The following is a description of a gene set: Human Gene Set: PHONG_TNF_TARGETS_DN from publication Phong MS, Van Horn RD, Li S, Tucker-Kellogg G, Surana U, Ye XS (PMID 20516219) species: Homo sapiens Genes down-regulated in Calu-6 cells (lung cancer) at 1 h time point after TNF treatment. p38 mitogen-activated protein kinase (MAPK) is rapidly activated by stresses and is believed to play an important role in the stress response. While Chk1 is known to mediate G(2) DNA damage checkpoint control, p38 was also reported to have an essential function in this checkpoint control. Here, we have investigated further the roles of p38 and Chk1 in the G(2) DNA damage checkpoint in cancer cells. We find that although p38 activation is strongly induced by DNA damage, its activity is not required for the G(2) DNA damage checkpoint. In contrast, Chk1 kinase is responsible for the execution of G(2) DNA damage checkpoint control in p53-deficient cells. The inhibition of p38 activity has no effect on Chk1 activation and gamma-H2AX expression. Global gene expression profiling of cancer cells in response to tumor necrosis factor alpha (TNF-alpha) revealed that p38 plays a strong prosurvival role through the coordinated downregulation of proapoptotic genes and upregulation of prosurvival genes. We show that the inhibition of p38 activity during G(2) DNA damage checkpoint arrest triggers apoptosis in a p53-independent manner with a concurrent decrease in the level of Bcl2 family proteins. Our results suggest that although p38 MAPK is not required for the G(2) DNA damage checkpoint function, it plays an important prosurvival role during the G(2) DNA damage checkpoint response through the upregulation of the Bcl2 family proteins., and this is the list of marker genes: HOXA9, HES1, SNCA, ID2, IVNS1ABP (influenza virus NS1A binding protein), ID1, ZNF131, HEY1